Given this list of marker genes Atp2a2, Atp2a3 (ATPase, Ca++ transporting, ubiquitous), Tmem94, Tap2, Tap1, here is a description of the gene set: species: Mus musculus The directed movement of substances from the cytosol to the endoplasmic reticulum of a cell. Mouse Gene Set: GOBP_CYTOSOL_TO_ENDOPLASMIC_RETICULUM_TRANSPORT